The following is a description of a gene set: A cellular anatomical entity that is part of an axoneme consisting of a doublet microtubule. Mouse Gene Set: GOCC_AXONEMAL_DOUBLET_MICROTUBULE species: Mus musculus, and this is the list of marker genes: Spmip8, Cfap206, Cfap107, Ribc1, Tssk6, Efhb, Tekt4, Cfap20, Cfap68, Nme7, Pierce1, Spmip10, Enkur, Tektip1, Cfap73, Spmip6, Tekt1, Saxo4, Tekt5, Spmip5, Cimip2b, Cfap53, Cfap210, Cfap161, Cfap144, Cfap90, Cfap45, Cfap276, Tektl1, Spag8, Tekt2, Cimip2c, Ribc2, Cfap126, Cfap52, Efhc1, Cfap141, Cfap100, Cfap77, Efhc2, Spmip9, Efcab6, Mns1, Pacrg, Dusp21, Spmip11, Tekt3, Dusp3, Cimip2a, Cfap95, Spaca9, Pierce2